The following is a description of a gene set: species: Mus musculus The process whose specific outcome is the progression of the corpus callosum over time, from its formation to the mature structure. The corpus callosum is a thick bundle of nerve fibers comprising a commissural plate connecting the two cerebral hemispheres. It consists of contralateral axon projections that provide communication between the right and left cerebral hemispheres. Mouse Gene Set: GOBP_CORPUS_CALLOSUM_DEVELOPMENT, and this is the list of marker genes: Wdr89, Szt2, Herc1, Nin, Coro1c, Ptprs, Filip1, Lpar1, Ephb3, Ephb2, Tsku, Bhlhe22, Wdr37, Prdm8, Rtn4rl1, Cdk5, Ryk, Pafah1b1, Dmxl2, Kcna1, Nsun5, Rpgrip1l, Grcc10, Atg16l1, Zeb2, Kcnc1 (potassium voltage gated channel, Shaw-related subfamily, member 1), Rtn4rl2, Kcna3, Kcna2, Rtn4r, Ulk4, Kif21b, Wdr47